Given this list of marker genes NR2F1, TVP23C, EHD3, EPPIN-WFDC6, APOBEC2, TENM4 (NCBI Gene Id 26011), ELFN2, UBXN10, APOLD1, LYN, SMAP2, ZSCAN31, RXRA, PCBP3, SFMBT1 (NCBI Gene Id 51460), ZCCHC2, CDH11, IGF1, TARS3, MYO5A (NCBI Gene Id 4644), SLC24A4, PHKA1, SPDYE1, SMARCC2, PTPN1, CHD3, M6PR, SETD3, ZNF618, SPDYE3, PKHD1, IGFBP5 (NCBI Gene Id 3488), NKAIN1, AGAP1, LRP11, AADACL3, FAM168A, CNOT9, GMEB2, ZBTB7C, ZNF629, NUP160, PITPNC1, LBX2, SPDYE5, GABBR2, CASZ1, PDE3B, FBXW11, SLC25A30, KSR2, SCYL2, ZNF514 (NCBI Gene Id 84874), MANEA, CSF1, EYA2, CHRNA1, GPATCH2L, AGFG2, PLCB1, ING5, TBC1D16, SAE1, MAP1A, SPEG, NRXN1, CARMIL1, CCNT1, LRCH4 (NCBI Gene Id 4034), PRKACG, HEG1, TMCC2, ELF3, SERTAD4, ZBTB37, UBE3D, CCBE1, SPR, NMUR2, ZFYVE27, TNFRSF13B, GRIA3, here is a description of the gene set: from publication Chen Y, Wang X (PMID 31504780) Human Gene Set: MIR6769B_3P Genes predicted to be targets of miRBase v22 microRNA hsa-miR-6769b-3p in miRDB v6.0 with MirTarget v4 prediction scores > 80 (high confidence targets). studied in species Homo sapiens